Given this list of marker genes SERPINC1, G6PC1, CYP39A1, MT1X, ALDOB, AGT, ADH4, SLC37A4, DOCK7-DT, SIRT4, CPB2, SMLR1, PGRMC1, PLG, CPS1, ABCC2, PEBP1, SLC38A4, SPRYD4 (NCBI Gene Id 283377), SLCO1B1, PRAP1, FMO5, LIPC, GPER1, APOB, SLC39A5, CD302, SARDH, SERPINA10, AKR1C3, FLRT3, ADAMTS16, SEMA4G, SERPIND1, CYP4A11, ASS1, AGXT, AKR1C2, ITIH1, AHSP, PRODH2, LINC02301, VTN, DHCR24, ALB, BHMT, ALDH6A1, HRG, ADH6, AHSG, SLCO1B3, MAT1A, ACY1, SCD (stearoyl-CoA desaturase), FTCD, MSI1, GOLT1A, TMPRSS6, LINC02851, AMBP, PAH, NBEAP1, ERP27, ADH1A, FABP1 (NCBI Gene Id 2168), RBP4, TENM1, FGG, SLC2A2, TFR2, AFP (alpha fetoprotein), ASGR1, PHYH, LINC02027 (long intergenic non-protein coding RNA 2027), GLS2, ASGR2, MEP1A (NCBI Gene Id 4224), MIR9-1HG, MT1F, CYP4F3, ACADSB, NAT1, HBM, FGFR4, DPYS, KLHL31, A1CF, MT2A, PNPLA3, APOA1 (NCBI Gene Id 335), RIDA, TMEM97, IDI1, PROX1, REEP6, ABCB11, CYP8B1, C4BPB, CYP3A7, GSTA1, SERPINA1, MST1, GC, DDC, ANGPTL3, TM4SF4, MLXIPL, MASP2, SERPINF2, MSMO1, FZD5, BEX1, MT1H, BAAT, UGT2B4, TDO2, BDH1, ATF5, F13B, TTR, SLC13A5, TM7SF2, PIK3C2G, MMAB, COL2A1, HSD17B11, XPNPEP2 (NCBI Gene Id 7512), ARG1, AMN, TF, FGB, GPAM, C8A, GSTZ1, PBLD, MPST, APOA2, APOH, CBS, SOAT2, PAQR9, DHCR7, SERPINA6, DIO1, HJV, C5, BCHE, ESPN, HPX, KLB, AK4, SERPINA4, FGA, PRG4, DGAT2, KNG1, LRG1, MT1E, HRG-AS1, HISLA, SLC38A3, ALDH4A1 (NCBI Gene Id 8659), ABCC6, MT1G, F2, STEAP2-AS1, APOM (NCBI Gene Id 55937), F12, APOC3, ITIH3, SLC30A10 (solute carrier family 30 member 10), SERPINA5 (serpin family A member 5), ITIH2, HMGCS2, here is a description of the gene set: studied in species Homo sapiens Marker genes curated from the annotated cluster as represented in the Descartes Human Gene Expression During Development database. from publication Cao J, O'Day DR, Pliner HA, Kingsley PD, Deng M, Daza RM, Zager MA, Aldinger KA, Blecher-Gonen R, Zhang F, Spielmann M, Palis J, Doherty D, Steemers FJ, Glass IA, Trapnell C, Shendure J (PMID 33184181) The gene expression program underlying the specification of human cell types is of fundamental interest. The study authors generated human cell atlases of gene expression and chromatin accessibility in fetal tissues. For gene expression, the study authors applied three-level combinatorial indexing to >110 samples representing 15 organs, ultimately profiling ~4 million single cells. The study authors leveraged the literature and other atlases to identify and annotate hundreds of cell types and subtypes, both within and across tissues. Our analyses focused on organ-specific specializations of broadly distributed cell types (such as blood, endothelial, and epithelial), sites of fetal erythropoiesis (which notably included the adrenal gland), and integration with mouse developmental atlases (such as conserved specification of blood cells). These data represent a rich resource for the exploration of in vivo human gene expression in diverse tissues and cell types. Human Gene Set: DESCARTES_FETAL_PLACENTA_AFP_ALB_POSITIVE_CELLS